Given this list of marker genes UBQLN2, HCCS, SMC1A, DKC1 (dyskerin pseudouridine synthase 1), PDHA1, WDR45, FLNA, COX7B (NCBI Gene Id 1349), AMELX, PHEX, DDX3X, NEXMIF, G6PD, FHL1, FMR1, NAA10, CASK, ALAS2, TLR7, ACSL4, GDI1, EFNB1, IKBKG, PORCN, HDAC6, CDKL5, MECP2, LAMP2, NSDHL (NCBI Gene Id 50814), IQSEC2, CCNQ, SLC35A2, AMER1, ZMYM3, RPS6KA3, RNF113A, ATRX, CLCN4, MSL3, COL4A5, HSD17B10, BCOR, HDAC8, TCEAL1, F8, EBP, USP9X, SYN1, MED12, DIAPH2, ZC4H2, KDM6A, NHS, NDUFB11, EDA, SMPX, GPR101, OFD1, PDK3, HNRNPH2, GJB1, SRY, here is a description of the gene set: A mode of inheritance that is observed for dominant traits related to a gene encoded on the X chromosome. In the context of medical genetics, X-linked dominant disorders tend to manifest very severely in affected males. The severity of manifestation in females may depend on the degree of skewed X inactivation. X-linked dominant inheritance species: Homo sapiens Human Gene Set: HP_X_LINKED_DOMINANT_INHERITANCE